The following is a description of a gene set: Human Gene Set: GOBP_POSITIVE_REGULATION_OF_PEROXISOME_PROLIFERATOR_ACTIVATED_RECEPTOR_SIGNALING_PATHWAY Any process that activates or increases the frequency, rate or extent of the peroxisome proliferator activated receptor signaling pathway. studied in species Homo sapiens, and this is the list of marker genes: LEP, LMO3, ASXL2 (ASXL transcriptional regulator 2), CITED2, PTGIS, GPS2, BMP2, JUND (JunD proto-oncogene, AP-1 transcription factor subunit), FABP5, ALOX15B